The following is a description of a gene set: Human Gene Set: chr11q25 species: Homo sapiens, and this is the list of marker genes: GLB1L3 (NCBI Gene Id 283176), RN7SL167P, RNU6ATAC12P, MIR4697, SNX19, NTM-AS1, NCAPD3, B3GAT1, PTP4A2P2, LINC02697, B3GAT1-DT, LINC02743, NTM-IT, LINC02706, OPCML-IT2, OPCML-IT1, THYN1, OPCML, JAM3, SPATA19, IGSF9B, ENSG00000301392, LINC02731, LINC02730 (long intergenic non-protein coding RNA 2730), GLB1L2, NTM, LINC02717, ACAD8, VPS26B, ENSG00000237654, LINC02714, LINC02684 (long intergenic non-protein coding RNA 2684)